The following is a description of a gene set: Mouse Gene Set: GOBP_REGULATION_OF_RESPONSE_TO_OXIDATIVE_STRESS Any process that modulates the frequency, rate or extent of response to oxidative stress. studied in species Mus musculus, and this is the list of marker genes: Stox1, Tbc1d24, Sesn3, Reg3b, Prkn, Macroh2a1, Rbx1, Aifm2, Met, Oxr1, Abcd1, Hspb1, Slc7a11, Mapkap1, Pnpla8, Selenon, Sesn1, Gch1, Tsc1, Slc25a14, Cd36, Ncoa7, Alox5, Hdac6, Sesn2, Ggt7, Nfe2l2, Pink1, Trpm2 (transient receptor potential cation channel, subfamily M, member 2), Scly, Keap1, Tldc2, Meak7, Dhfr, Adcyap1r1, Fbln5, Usp25, Rbx1-ps, Epor, Fads2, Rnf146, Mctp1, Fut8